Given this list of marker genes GUSB, here is a description of the gene set: Reactome Pathway: MPS VII - Sly syndrome (Hyaluronan metabolism) part of: Mucopolysaccharidoses Mucopolysaccharidosis type VII (MPS VII, Sly syndrome, beta-glucuronidase deficiency; MIM:253220) is an autosomal recessive lysosomal storage disease characterized by a deficiency of the enzyme beta-glucuronidase (GUSB; MIM:611499) which would normally cleave glucuronide residues from dematan sulphate, keratan sulphate and chondroitin sulphate, resulting in build up of these GAGs in cells and tissues. The gene encoding GUSB is 21 kb long, contains 12 exons and gives rise to two different types of cDNAs, through an alternate splicing mechanism. It maps to 7q11.21-q11.22. The phenotype is highly variable, ranging from severe causing death, non-immune hydrops fetalis to mild forms with survival into adulthood. Most patients with the intermediate phenotype show hepatomegaly, skeletal anomalies, coarse facies, and variable degrees of mental impairment. species: Homo sapiens